Given this list of marker genes GIP, TRPM5, SIRT3, ATP13A2, PARD6A, FGA, TRPA1, VSNL1, MLXIPL, P2RX7, VPS35, PRKN, MYO18A, PPID, GOLPH3, DNM1L, NNAT, CFTR, ABCG1, PRKCA, GPR27, HCAR2, FUT10, ADAM9, HLA-DRB1, RAC1, PFKFB2 (NCBI Gene Id 5208), ANO1, PPARD, BAIAP3, OXCT1, PFKM, PDX1, FUT11, PRKCE, ADAM8, PTPN23, TTN (titin), CD2AP, GHRL, BMP6, TGFB1, GPLD1, PSMD9, CHRM3, PRKAR1A, PCK2, CD33, JAK2, TGFB3, SERP1, BAD, GLUD1, PPP3CB, TMED10, IL13, RBP4, CAPN10, FFAR2, PLA2G1B (NCBI Gene Id 5319), ANG, MIR199B, FGB, UCN3, GPR68, ABAT, IER3IP1, FRMD4A, F2RL2, NR0B2, TMEM132A, TREM2, SIRT6, MYH10, FGG, GPER1, RAPGEF4, PPIA, NMU, SEC24A, GCG, EXPH5, CRH, ANKRD1, UNC13B, IRS2 (insulin receptor substrate 2), RFX6, PHPT1, TUNAR, DYNLL1, INS (insulin), ADCY8, TM7SF3, TARDBP, BLK, APBB1, SLC2A2, DOC2B, ABCC8, C1QTNF3, MCU, SYTL4, MYRIP, F2, MPC2, WLS, GCK, KCNN4, OR51E2, VEGFC, MYOM1, TCF7L2, SLC30A8, TLR4, BSG, ORAI1, PPARG, AACS, TGFB2, PLA2G6, GPRC6A, ACSL4, C2CD2L, NKX6-1, TRH, IL1A, F2RL1, HIF1A, NADK, SYBU, STX4, ACHE, GNA11, NR1H2, C1QTNF12, GOLPH3L, LRRC8A, NLGN2, PRKCB, SOX4, ADORA2A (NCBI Gene Id 135), PRKACA, RPH3AL, APBB3 (amyloid beta precursor protein binding family B member 3), IGF1, TRPM4, GIPR, ARF6, ISL1, PLCB1, TLR2, CD38, NR1H4, ITPR1, CASR, FFAR1, OSBP, here is a description of the gene set: studied in species Homo sapiens Human Gene Set: GOBP_POSITIVE_REGULATION_OF_PROTEIN_SECRETION Any process that activates or increases the frequency, rate or extent of the controlled release of a protein from a cell.